Given this list of marker genes Cul4a, Kdm1a, Ddb1, Trp53inp1, Nscme3l, Nfatc4, Dhx36, Opn1sw, Rpl26, Triap1, Pold1, Cops9, Prkcd, Pcna, Mme, Aurkb, Tmem161a, Yy1, Pold3, Ei24, Ddb2, Zbtb1, Atr, Cers1, Rnf168, Mapk9, Mc1r, Mapk14, Cul4b, Pierce1 (NCBI Gene Id 69327), Crebbp, Xpa, Mmp1b, Cdkn1a (NCBI Gene Id 12575), Sde2, Actr5, Bax (BCL2-associated X protein), Pola1, Mapk11, Ep300, Fbxw7, Nsmce3, N4bp1, Polh, Eif2ak4, Rhno1, Crip1, Poli, Agap3, Pbk, Casp9, Bmf, Stk11, Opn5, Hyal2, Nedd4, Usp28, Mapk13, Ercc4, Mmp9, H2ac25, Trex1, Map3k20, Hyal1, Ptprk, Noc2l, Mmp3, Mfap4, Nlrp1a, Timp1, Mmp1a, Opn3, Trp53, Pik3r1, Ppid, Sirt1, Parp1, Rbx1-ps, Eif2s1, Xpc, Hyal3, Ruvbl2, Rad23b, Ercc1, Cdc25a, Rad23a, Rhbdd1, Rbx1, Smpd1, Npm1, Mmp2, Mettl3, Bak1, Ino80, Polk, Aqp1, Nlrp1b, Mdm2, Ddias, here is a description of the gene set: Mouse Gene Set: GOBP_CELLULAR_RESPONSE_TO_UV species: Mus musculus Any process that results in a change in state or activity of a cell (in terms of movement, secretion, enzyme production, gene expression, etc.) as a result of an ultraviolet radiation (UV light) stimulus. Ultraviolet radiation is electromagnetic radiation with a wavelength in the range of 10 to 380 nanometers.